Given this list of marker genes Pkd2, Pkd1, Irx3, Wnt7b, Aqp1, Dll1, Hes5, Pou3f3, Irx1 (NCBI Gene Id 16371), Irx2, Jag1, Umod, here is a description of the gene set: Mouse Gene Set: GOBP_LOOP_OF_HENLE_DEVELOPMENT studied in species Mus musculus The process whose specific outcome is the progression of the loop of Henle over time, from its formation to the mature structure. The loop of Henle is a nephron tubule that connects the proximal convoluted tubule to the distal convoluted tubule.